Given this list of marker genes RNF168, KANSL1, F8, NFIA, SPARC, CNTNAP2, LMBRD1, MARS2, ADA2, PET100, here is a description of the gene set: Intraventricular hemorrhage studied in species Homo sapiens Human Gene Set: HP_INTRAVENTRICULAR_HEMORRHAGE Bleeding into the ventricles of the brain.